Given this list of marker genes Pten, Kcnk2, Abraxas2, Dab2ip (NCBI Gene Id 98996), Rcor2, Smad6, Tbc1d30, U2surp, Dbndd2, Itsn1, Bahd1, Kif9, Olfml3, Smarcad1, Marcksl1, Tes, Galnt17 (NCBI Gene Id 94250), Tub, Zfp609, Gabra1, Scn4b, Rarb, Pik3r5, Chl1, Phf21a, Pom121l12, Slc6a4, Mettl24, Sar1a, Ift122, Clcn6, Sec63, Rora, Parp16, Arnt2, Nrp1, Mvb12b (NCBI Gene Id 98948), Ppfia3, Bace1, Anxa8, Rab22a, Mfsd4b5, Sprn, Kcnab2, Shisa7, Wac, Fbxo33, Fmod, Celf1, Ky, Mmp2, Il7, Tdh, Dmtf1, Gdnf, Cxxc4, Larp1b, Prr14l, Clcn4, Trpm7, Sema4d, Tsr2, Krtap1-5, Exoc6b, Arrdc3, Tfap2a, Lrrtm3, Btrc, Rin2, Plekhg6, Krtap3-1, Nufip2, Ubiad1, Cxcl2, Trabd2b, here is a description of the gene set: Mouse Gene Set: MIR_6905_5P studied in species Mus musculus Genes predicted to be targets of miRBase v22 microRNA mmu_miR_6905_5p in miRDB v6.0 with MirTarget v4 prediction scores > 80 (high confidence targets). from publication Chen Y, Wang X (PMID 31504780)